The following is a description of a gene set: species: Homo sapiens Pathway Definition from KEGG: EGF -> EGFR -> JAK1 -> STAT1/3/5 EGF-Jak-STAT signaling pathway. Pathway ID: N00094. Pathway type: Reference. Pathway class: nt06262 Pancreatic cancer. Human Gene Set: KEGG_MEDICUS_REFERENCE_EGF_JAK_STAT_SIGNALING_PATHWAY, and this is the list of marker genes: JAK1 (Janus kinase 1), STAT5A, STAT5B, EGFR, STAT1, EGF, STAT3